Given this list of marker genes Dbf4, Lcorl, Ccnb1-ps, Ncapd3, Cdk5rap2, Ccdc122, Slbp, Brca1, Nuf2, Usp49, Zdhhc15, Tnfrsf11a, Rrm1, Ccnb2, Gm5327, Kcng3, Ranbp1, Aurka, Gabrp, Mcm7, Rbbp7, Slc35g1, Ahcyl, Dsg2, D430020J02Rik, Esr1, Kif2c, Cdca2, F3, Pigr, Mad2l1, Osr2, Fignl1, Bub1b, AA467197, Zranb3, Cenpa, Asf1b, Ska3, Hpf1, Stk39, Fat1, Gtse1, Cpe, Rad54b (RAD54 homolog B (S. cerevisiae)), Sectm1a, Ezh2, Cgas, Bard1, Dscc1, Col15a1, Anln, Tacc3, Kif20b, Ccnf, Rpa1, Slfn9, Apol9a (apolipoprotein L 9a), Pclaf, Mcm3, Ect2, Chaf1b, Hat1, Shcbp1, Rad51c, Aurkb, H2bc13, Ncapg (NCBI Gene Id 70636), Pkmyt1, Nsl1, E2f7, Rad51, Cenpn, Rfc5 (replication factor C (activator 1) 5), Cenpi, Cacnb3, Cenpu, Mapk13, Ltf, Mcm2, Ulbp1, Tpx2, Fhl2, Hmmr, Atad5, Nup205, Foxm1, Trim59, Pals2, Clip4, Pola2, Haspin, Exo1 (exonuclease 1), Ccna2, Ticrr, Tipin, Trip13, Cldn2, Golm1, Odf2l, Gas2l3, Bex3, Dpagt1, Rpa2, Klk13, Gsr (glutathione reductase), Cdkn3, Plk4, Fam167a, Rbm3, H2ac22, Clspn, Dtl, Ptges, Pold2, Top2a, Cdc25c, Blm, Psrc1, Slc25a13, Ppil1, Chek1, Klk10, Ankrd28, H2bc3, Atad2, Lig1, Cep55, Plek2, Mis18bp1, Egln3, Dut, Cdt1, Mcm5, Mcm4, Ccl28, Cfap20dc, Slc7a1 (solute carrier family 7 (cationic amino acid transporter, y+ system), member 1), D17H6S56E-5, Sorcs2, Epsti1, Ephb2, Pkm, Zgrf1, Tcf19, Vtcn1, Prr11, Cnot9, Naa50, Brca2, Gm16494, Tnip3, Pole, Zwilch, Topbp1, Nup155, Gm5431, Sgo1, Mrps16, Epcam, Gadd45g, Cenpe, Birc5, Efna5, Itgav, H1f0, Atp1b1, Polq, Pgk1, Smc2, Bora, Taf1d (TATA-box binding protein associated factor, RNA polymerase I, D), E2f8, Arhgap11a, Exosc2, Ammecr1, Slc7a5, Cdk1, Cip2a, Arhgap19, Spdl1, Ccdc34, Cenpf (centromere protein F), Kif22, Smarcc1, Muc5b, Tspan1, Tmem165, Smc4, Nt5c2, Mtfr2, Tpi1 (NCBI Gene Id 21991), Ddias (NCBI Gene Id 74041), Txnrd1, Gpsm2, Ttk, Brip1, Enc1, Bub1, Lmnb1, Neil3, Ehf, Stil, Spc24, Psat1, Dsn1, Sectm1b (secreted and transmembrane 1B), Pcna, Aspm, Racgap1, Casp8ap2, Fanci, Mki67, Cit, Areg, Chek2, Gins1 (NCBI Gene Id 69270), Wdr72, Prim1, Kif18a, Hjurp, Prim2, H1f5, Ncapd2, Dtymk (NCBI Gene Id 98609), Tfdp1, Hmgb2, Cep85, Kif14 (kinesin family member 14), Uck2, Cdc20, Tnfaip8l1, Nek2, Tyms, Pbk, Snrpd1, H2bc4, Tubg1, Ube2c, Ccnb1, Cdkn2a (NCBI Gene Id 18560), Tk1, Kif4, Spc25, Cdc25a, Knstrn, Dlgap5, Knl1, Cdca8, Kifc1, H2ac10, Ckap2, Prrg4, Usp1, Serpine1, Kpna2, Clcn5, Tube1, Atp1a1, Msh6, Kntc1, Esco2, Spats2, Cdkn1a, Mms22l, Oas1g, Cxcl17, H2bc12, Ndc80, Pmf1, Mastl, Spag5, Ccne2, 2700099C18Rik, Fkbp5, Wdr76, Nusap1, Ddit4, Ncapg2, Aldh18a1, Ssrp1, Eif2ak2, Mtbp, Gm6340, Eid3, Gm23557, Troap, Parpbp, Gm57857, Nasp, Prss35, Cd276, Smpdl3b, Cdkn1c, Pola1, Aqp4, Cdc6, Chaf1a, Arhgef39, Sdc1, Tnfrsf9, Fmn1, Ckap2l, St14, Casp3, Kif18b, Nsd2, Uhrf1, Cenpk, Ndc1, Depdc1a, Melk, Gins2, Rfc2, Wdhd1, Cdc25b, Iqgap3, H2ac11, Rnf128, Calml3, Tmem54, Kif23, Vill, Ipo5, Dhfr, Cdca5, Rfc4, Sytl5, Zfas1, Ppa1, Susd2, Fen1, Tceal9, Mcm8, Fanca, Mif (macrophage migration inhibitory factor (glycosylation-inhibiting factor)), Rangap1, Ints7, Hacd2, Trp53i11, Oip5, Mboat1, Mlkl, Rfwd3, Fancd2, Kif20a, Gm22806, Slc7a6, H2ac20, Apol9b, Firrm, Fbxo5, Clu, Nop58, Mthfd2, Me1, Prc1 (protein regulator of cytokinesis 1), Sgo2a, Dna2, Gcnt4, Ccne1, Kif15, Hells, Slc4a4, Gm21963, Ncaph, Zfp750, Plk1, Mcm10, Zfand4, Mdk, Kif11, 4930579G24Rik, Haus6, Pask, Cdca7, Ranbp17, Fam83d, Nrm, Kcnk1, Lnx1, Rfc3, Incenp, Muc5ac, Scarna17, Naaladl2, Zfp599, Mcm6, Sox2, Cdc45, Cdk2, Eri1, Mir5103, Ccdc18, Rad18, Skp2, Dnmt1, Tuba1c, Scara3, Cks2, Ckap4 (cytoskeleton-associated protein 4), Cenph, Galnt3, Cenpl, Diaph3, Neat1, Gen1, Rad54l, Rnaseh2b, here is a description of the gene set: Rb1<F/F>; Rbl1<-/->; Pten<F/F>; Trp53<F/F> mice were generated by breeding Trp53<F/F>; Pten<F/F> mice with Rb1<F/F>, Rbl1<-/-> mice. studied in species Mus musculus from publication Lázaro S, Pérez-Crespo M, Lorz C, Bernardini A, Oteo M, Enguita AB, Romero E, Hernández P, Tomás L, Morcillo MÁ, Paramio JM, Santos M (PMID 31611390) Genes differentially regulated in CMV-QKO LCNEC tumors from Rb1<F/F>;Rbl1<-/->;Pten<F/F>;Trp53<F/F> mice versus normal lung tissue. Mouse Gene Set: LAZARO_GENETIC_MOUSE_MODEL_HIGH_GRADE_LARGE_CELL_NEUROENDOCRINE_LUNG_CARCINOMA_UP